Given this list of marker genes MKS1, LRBA, DOCK8, PGM3, VPS51, SUFU, LIFR, FOXH1 (NCBI Gene Id 8928), CEACAM3, TALDO1, SEC24C, NOD2, IDS (NCBI Gene Id 3423), ARVCF, WDPCP, WDR11, GP1BA, FGFR1, SCLT1, BBS4, CDC42BPB, ERI1, TNF, ALOX5 (arachidonate 5-lipoxygenase), RELB, TBCK, SLC9A3, GGT1, HMGA2, GNB1, COX4I2, LYN, AFF4, MKKS, LZTFL1, TRAIP, FGF8, BBS9, SCAPER, BBS12 (NCBI Gene Id 166379), RFX7, FBXO11, ARSL, BBIP1, PTGER2, IFT74, IL6ST, CARD11, HIRA, FCGR2A, BBS2, SLC26A9, PLCG2, CDSN, BBS5, BCL11B, ARL6, ERCC2, GLI2, CEACAM6, CDKN1C, CRIPTO, IL13, IGF2, NFKB2, SERPINA1, NKX2-1, KCNN4, FOCAD, TRIM32, IFT27, DPP9, GAS1, PEPD, ODAD3, SIK3, FOXP2, CEP290, RIC1, LIG4, HNMT, GNB2, HMOX1, HFE, SLC11A1, EDNRA, COMT, PTCH1, IFT56, EP300 (NCBI Gene Id 2033), UBAP2L, CFAP418, SPINK5, ZNF699, NEK9, CCL11, CARD10, TGFB1, SLC27A4, JMJD1C, PEX5, AGR2, PLAG1, CEP19, MIA3, CFTR, DLL1, BBS10, HLA-G, GRHL2, ODC1, GP9, SIX3, CLCA4, CASP8, GP1BB, IPO8, STX1A, STXBP1, ZIC2, SHH, STAT6, SCGB3A2, WAC, CDON, SDCCAG8, NPHP1, FLG, SLC6A14, NODAL, MUC7, BBS1, UFD1, C4B, CREBBP, MTOR, BBS7, IGHG2, TBX1, GCLC, MIF, ALG9, TGIF1, SDHD, DDX41 (DEAD-box helicase 41), TTC8, SCN4A, LMX1B, IFT172, CCDC28B, DCTN4, IGKC, GSTM3, ADA, TBX21, JAK1, NSUN2, ALMS1, DISP1, CARMIL2, ELOVL4, USP7, RREB1, UNC45A, here is a description of the gene set: studied in species Homo sapiens Human Gene Set: HP_ASTHMA Asthma Asthma is characterized by increased responsiveness of the tracheobronchial tree to multiple stimuli, leading to narrowing of the air passages with resultant dyspnea, cough, and wheezing.